The following is a description of a gene set: species: Homo sapiens Human Gene Set: MIR6868_5P from publication Chen Y, Wang X (PMID 31504780) Genes predicted to be targets of miRBase v22 microRNA hsa-miR-6868-5p in miRDB v6.0 with MirTarget v4 prediction scores > 80 (high confidence targets)., and this is the list of marker genes: JADE2, SIRT1, NAV3, FOXN2, ITPR3, ABRAXAS2, KLHL4, HINFP, CNOT7, USP49, IFFO1, VASH1, RAB27B, SDK2, MCTP1, EGLN1, ASIC2, IGF2BP2, KCNH7, RIOK3, ARC, AMD1, RDH11, ASTN1, OSTF1, PTBP3, TPTEP2-CSNK1E, RAD51D, FBXO33, CRYGS, IGF2BP1, SURF4, PPP1R9B, SPOCK3, PON2, EPHA4, ABR, AEBP2, E2F3, C1QTNF9B, FAM171A1, ABHD5, JAM2, WRNIP1 (WRN helicase interacting protein 1), RARB, SOCS7 (NCBI Gene Id 30837), SMIM5, STAG2, MTMR4, MAP2, MYLK, ACVR1, ZBTB34, ETV4, NPTXR, ACSM5, DENND2B, C14orf132, SLC37A3, SV2C, NDRG3, HAPSTR1, ANK3, PJA2, UBE2G1, HP1BP3, YBX2, DCAF10, CDCA7L, RNF185, ATF7, JAG1, SIDT1, NEK4, YY1, GOLGA7, RGS8, RNH1, SERPINF2, LIMA1, TAX1BP3, MEX3C, LRRC28, CCDC149, WDTC1, ZNF835, NAA30 (NCBI Gene Id 122830), FIGN, CSNK1E, SENP3, FOXJ3, ACBD3, CAPRIN2, TMPRSS11E, CDK13, ATP2B1, CSGALNACT1, SAMD12, ZNF707, UBAP1, KCNK2, BBX, MAP1A (NCBI Gene Id 4132), COBLL1, C9orf152, CRYGN, HOXB4, TPD52, DUOX2, PEAR1, EML5, CSF1, THUMPD3, PKHD1, PLPPR1 (phospholipid phosphatase related 1), GATA3, IL2RB, SLC12A2, HYCC2